The following is a description of a gene set: Monocyte-derived dendritic cells (DC) and macrophages (MΦ) generated in vitro from the same individual blood donors were exposed to five different pathogens, and gene expression profiles were assessed by microarray analysis. Responses to Mycobacterium tuberculosis and to phylogenetically distinct protozoan (Leishmania major, L. donovani, Toxoplasma gondii) and helminth (Brugia malayi) parasites were examined, each of which produces chronic infections in humans yet vary considerably in the nature of the immune responses they trigger. from publication Chaussabel D, Semnani RT, McDowell MA, Sacks D, Sher A, Nutman TB (PMID 12663451) Genes up-regulated in comparison of dendritic cells (DC) exposed to T. gondii versus DCs exposed to M. tuberculosis. Human Gene Set: GSE360_T_GONDII_VS_M_TUBERCULOSIS_DC_UP studied in species Homo sapiens, and this is the list of marker genes: RPL12, ORC1, SH3YL1 (SH3 and SYLF domain containing 1), ADD3, PMP22, RAB40A, DAG1, SUGP2, HARS1, LPCAT1, CDK9, TES, COLQ, ASGR1, BDH1, H6PD, FARP1, ALOX15, UPK3A, MATN2 (NCBI Gene Id 4147), RAB32, NBAS, FOLH1, SPINT2, NFIC, FOXN3 (forkhead box N3), GHRHR, GFI1, SIKE1, RAPGEF4, CSNK1E, COL4A5, CAMK2B, C2CD2, ADAM11, TRAPPC12, ATP5MC2, ALOX15B (arachidonate 15-lipoxygenase type B), PEMT, TRAF4, NPRL2, BAAT, B3GNT3, CERNA1, ALDH5A1, CLNS1A, PYGB, ASNS, COL9A2, ADCY3, ZSCAN9, HLX, IP6K1, DNASE1L3, MRPL49, CRH, RNF44, KIFC1, SPIDR, SLC1A2, PCBP4, GARS1, SLC1A5, MAGEA10, HDC, SLC29A1, CLPX, EXOSC2, CRYM, GFUS, TMSB15A, AMFR, ASCC3, EIF3J, SDHA, ALDH3A2, CDC5L, UQCRC1, IGFBP5, KAT7, UBN1, GLRA3, FNTB, P2RY14, HBE1, COL9A3, TP53BP1, SEC31A, SIAH1, COQ9, RAE1, SERINC5, TRAPPC3, HDAC5 (NCBI Gene Id 23342), KCNB2, NACA, SRD5A1, ZFR2, SEMA4D, ALDH2, RGS10, ICAM3, OFD1, SETD1A, RFXAP, AHSG, PITPNM1, CCDC9, PROZ, ABCG1, IL1A, STAR (steroidogenic acute regulatory protein), PHACTR1, CHAF1B, AK1, GGA3, AHCY, UNC93A, PROM1 (NCBI Gene Id 9634), CHD3, UMPS, TIAM1, CRADD, RCVRN, OTUB1, CD200, PPOX, CBX7, SHH, SLC12A3, ZNF81, CNGA1, NFIL3, UPF3A, CEBPG, COX7C, TMSB4Y, RRP1B, SREBF1, TELO2, NCR2, TRIO, AMOT, SAPCD1, AARS1, THAP12, CREBZF, KRT10, EIF1AX, CELF2, SARM1, TRAF5, MAN1C1, TTC22, ABCD2, AMT, CPNE1 (copine 1), MS4A3, HMGCS2, MTSS1, KTN1, PKD1, HERPUD1, TMEM109, MDM2, PGAP4, EXD2, AUH, PTH1R, ARHGEF18, SHB, MYOM2, LY75, HBBP1, TAF1B, CAMK2A, KRT16, TMPRSS11D, HEBP2, PLA2G5, SPINT1, SLC25A14, TM7SF2, STK16, CHD4, CX3CL1, REEP2, ADNP, CXCR4, USP22, MXRA7, RRS1 (NCBI Gene Id 90810), MLF2, KCNQ1, LGALS2, HOMER2, ALX1, MARS1, GUCY1B1, CBS